The following is a description of a gene set: Human Gene Set: GOBP_ORGANIC_HYDROXY_COMPOUND_TRANSPORT species: Homo sapiens The directed movement of an organic hydroxy compound (organic alcohol) into, out of or within a cell, or between cells, by means of some agent such as a transporter or pore. An organic hydroxy compound is an organic compound having at least one hydroxy group attached to a carbon atom., and this is the list of marker genes: MIR27A, DRD3, APOA2, ADORA3, SYT1, SLC18A2, SYK, TAC1, COMMD1, SLC5A8, VPS4B, DTNBP1, SLCO1B3-SLCO1B7, FLVCR1, SYT11, FFAR3, SLC22A3, GRAMD1C, REN, SOAT2, ABCG8, CETP, SHH, WNK4, OSBPL3, SLC10A4, AQP1, MSR1, ABCA2, MAPK15, APOE, RALBP1, SDHD, SLC27A5, NUS1, NAXE, CHRNB2, STRA6, TGM2, KCNK9, ARV1, MIR19B1, MIR33B, LRP1, CHRNA4, CXCL12, SLC5A12, STARD4, CRHR1, ADORA2A, ABCA13, TMEM97, MIR185 (NCBI Gene Id 406961), GRAMD1A, GPS2, ABAT, ABCA5, PLTP, SPG11, P2RY1, ABCG4, FCER1G, CYP19A1, MIR613, SLC16A8, APOA1, GDNF, ABCB11, AQP7, VPS54, SLC10A5, AQP11, FGF19, ADRA2C (adrenoceptor alpha 2C), OSBPL9 (NCBI Gene Id 79638), TSPO, SLC51A, ABCD3, ABCC3, SLC6A2, SLC22A24, SCARB1, MYB, KCNA2, FURIN, FGF20 (fibroblast growth factor 20), PPARG, ABCC2, GRM2, ABCA8, ADIPOQ, SNCA, SLC16A1, ANXA2, LDLR, ACTB, SLC29A3, ARL8B, ABCA3, ATP8B1, MIR130B, MIR93, SELENOM, CEACAM1, AQP9, AQP7B, CHGA, SLC5A1, MIR148A, ABCA12, APOF, AQP10, OSBPL7, ZDHHC8, SLC49A4, VPS4A, OSBPL6, KCNQ1, TSKU, NPY2R, DRD1, NPC1L1, NPC2, SLC51B, ABCA7, PON1, SEC24A, DAB2, GHRL, LILRB1 (NCBI Gene Id 23445), SLCO1B1, MIR27B, BMP6, NFKBIA, ADRA2A, ABCA4, FLVCR2, ABCG1, SCP2, MIR206, NR1H3, NPC1, AGTR1 (NCBI Gene Id 9449), DRD2, MFSD10, CHRM5, APOC1, EMB, VPS51, NMB, PINK1, RBP4, SLC5A11, CARTPT, SLC5A3, SLC6A3, SLC44A1, SLC2A13, TOR1A, ABCA1, SLCO1C1, SLC22A1, NFKB1, YJEFN3, SLC18A1 (solute carrier family 18 member A1), CAV1, SLC10A1, ADRA2B, SREBF2, MIR128-1, PTCH1, PCSK9, MIR17, TREM2, NR0B2, MIR9-1, SLC18A3, OXT, SLC44A2, SLC10A3, ABCC4, CHRNA6, NR1H2, MECP2, GPM6B, SLCO1B3, GRK2, VPS52, EGF, TSPO2, LCAT, GALR1, VAPB, KDM5B, AKR1C1, LIPC, LIPG, AGT, ASIC3, STARD3NL, ECRG4, P2RX1, SLC10A2, TTC39B (NCBI Gene Id 158219), COMT, OPRK1, TMF1, GAL, SNCG, SLCO1A2, SLC22A2, MIR302A, SIRT1, PRKN, SLC10A6, APOA5, GHSR, OSBPL5, SLC26A6, RAB3B, STAR, VIP, CFTR (CF transmembrane conductance regulator), GABBR1, MIR301B, POMC, ABCB4, SLC16A3, STX12, CRH, SLCO1B7, GNAT1, KCNB1, GRAMD1B, RXRA, VAPA, AQP3, PLA2G10, APOC2, SOAT1, SPP1, KPNA4, SLC19A3, MAPK3, LIPA (lipase A, lysosomal acid type), APOA4, RELCH, SLC19A2, OSBP, MIR145, SLC16A7 (solute carrier family 16 member 7), NOS1, NR1H4, AQP2, LAMTOR1, EEPD1, MIR144, SLC6A4, ABCC11, DRD4, HTR1A, PARK7, SLC29A4, CYP7A1, OSBPL2, OSBPL1A, PTPN11, APOC3, MIR26A1, ABCG5, PIP4K2A, MIR33A, ANXA2P2 (NCBI Gene Id 304), TPCN2, STARD3, ITGB3, MTTP, CD36, APOB, SYT7, C1QTNF1, MIR758, SLC18B1, HTR1B, STX1A, LDLRAP1, SYT4, VPS53 (VPS53 subunit of GARP complex), SERAC1, CLU, STARD5, ACACB, CES1, HTR2A, AKR1C4, APOM, SLCO2B1